The following is a description of a gene set: species: Homo sapiens Genes distinguishing vincristine resistant and sensitive B-lineage ALL; here - genes up-regulated in the drug resistant samples. Childhood acute lymphoblastic leukemia (ALL) is curable with chemotherapy in approximately 80 percent of patients. However, the cause of treatment failure in the remaining 20 percent of patients is largely unknown. Human Gene Set: HOLLEMAN_VINCRISTINE_RESISTANCE_B_ALL_UP from publication Holleman A, Cheok MH, den Boer ML, Yang W, Veerman AJ, Kazemier KM, Pei D, Cheng C, Pui CH, Relling MV, Janka-Schaub GE, Pieters R, Evans WE (PMID 15295046), and this is the list of marker genes: NFATC1, TBC1D9, YRDC, POM121, CHCHD7, MTF2, RUFY3, SOX11, KDM4B, MTMR9, LBH, PISD, PSME4, PPM1B, BTBD3, KCNN1, SH3GL1, EFNB2, HLA-DQA1, ZNF512B, ZNF263, TRIM24, CALU, SPATA2, RUBCNL, DSC3, ARHGAP29, ELOA, TCFL5, DIDO1, CREB3L2, ZNF304, BCL11B, MXD1, PLCXD1, RBMS1, CRMP1, ABHD3 (NCBI Gene Id 90492), PNN